The following is a description of a gene set: from publication Zhang L, Long W, Xu W, Chen X, Zhao X, Wu B (PMID 35669188) Mouse Gene Set: ZHANG_UTERUS_C7_EPITHELIAL2_CELL Table S2: Representative genes of each cell cluster species: Mus musculus, and this is the list of marker genes: Eif3c, Naaa, Ptma, Gm6136, Rps26-ps1, Lsm2, Atp5f1b, Sprr2g, Gipc1, Eif2s1, Ap2s1, Rpl35a-ps2, Cks1b, Tpm3, Cox5a, Elf3, Calr, Ly6a, Tomm5, Plpp2, Hmgn2, Abcf1, Ap2m1, Prom1, Psme2b, Timm13, Srsf3, Rrm1, Ap1m2, Lcn2, Lrrc59, Rpl38-ps2, Rpl22l1, Avpi1, Fuca2, M6pr, Clic1, Crip1, Bmyc, Ccdc12, Mad2l1, Dtymk (NCBI Gene Id 98609), Cttn, Rpl37rt, Eif6, Pglyrp1, Ccnd1, Rab32, Gm15501, Samm50, Dpy30, Tonsl, Cct3, Cib1, Smarca4, Fxyd3, 2200002D01Rik, Ormdl2, Stip1, Gm7536 (predicted gene 7536), Impdh2, Ybx1, Rps10-ps1, Atp5mc2, Nudcd2, Cisd1, Bcap31, Sat1 (spermidine/spermine N1-acetyl transferase 1), Ubl4a, Hnrnpu, Rps10-ps2, Elavl1, Ybx3, Ccdc124, Fxyd4 (FXYD domain-containing ion transport regulator 4), Tma7, Syngr2, Lap3 (NCBI Gene Id 66988), Xpnpep1, Pno1, Naca, Ywhah, Cct2, Acp1, Cdc42ep5, Metap2, Atp5mg, Mrps33, Padi4, Rpf1, Rpl7a, Ndufb7, Mrpl28, Rpl13a, Tagln2, Sdhd, Hsd17b12, Usp50, Urah, Por, Fam20c, Gale, Gadd45gip1, Sap18, Rps11, Rps27l, Gm8730, Ywhae, Rps6, Plscr1, Rpl28-ps1, Rnf128, Bzw1, Tpd52l1, Gapdh, Tmprss4, Gm8355, Rps10, Gars1, Uqcrc1, Gm9385, Fam107b, Cops5, Cct5, Gpx1, Rpl14-ps1, Llph, Tmem213, Mrps18a, Gm7730, Mrps21, Tmem208, Kif5b, Msmo1 (NCBI Gene Id 97453), Mtx2, Rn18s-rs5, Rpl7, Atp5mk, Rab25, Arpc1b, Cdc42se1, Timm23, Polr2f, Anxa4, Hnrnpm, Rps2 (ribosomal protein S2), Cacybp, Gm14539, F2rl1, Rpl15, Nme1, Snrpa1, Serpinb1a, Mtch2, Gm10036, Hnrnpa2b1, Ndufc1, Gm15421, Itga6, Ebp, Rnpep, Krt18, Ndufa9, Padi2, U2af1, Tmod3, Gm10177, Cbx1, Uchl3, Sfn, Psme3, Erh, Plet1, Ssu72, Rpl6l, S100a11, S100g (S100 calcium binding protein G), Gng12, Timm50, Padi1, Wfdc2, Mrto4, Atp5mf, Cystm1, Tgm2, Psmd14, Ube2e1, Taldo1, Prxl2a, Psmd1, Dhcr24, Ncoa7 (nuclear receptor coactivator 7), Phlda1, Prmt1, Golm1, Prdx3, Pomp, Cd2ap, Gm12191, Rpl17-ps10 (ribosomal protein L17, pseudogene 10), Sgms2, Creld2, Ruvbl2, Atp1b3, Ndufs4, Cox6c2, Prkab1, Lad1, Rps6-ps4, Mydgf, Tspan1, Polr3k, Snrpe, Mrpl36, Clca1, Tubb4b, Mrpl46, Uba52, Bccip, Uba52rt, Tomm22, Plxnb2, Arpc5, Rtn4, Ezr, Ndufb3, Cox5b, Atp2c2, Pkm, Plaur, Yrdc, Rps24-ps3, Ap2b1, Bace2, Ap1s1, Gm13436, Gm11249, Skp1, Pdzk1ip1, Snrpd1, Psmb5, Ctnna1, Gm5905, Tmem14c, Acsl5, Pfdn6, Gm15500, Ran, Ppp1r14b, Pgk1, Ddx1 (NCBI Gene Id 104721), Hprt1, Adss1, Ltf, Tm9sf2, Ncstn, Fmc1, Erhrt-ps, Rps18-ps5, Nsun2, Ccnb2, Gm3150, Brix1, Serbp1, Vars1, Fuca1, Arpc2, Muc4, Nap1l1, Hnrnpk, Gm3375, Lsm8, Ier3 (NCBI Gene Id 15937), Serp1, Snrpa, Cyba (NCBI Gene Id 13057), Cox7b, Gm5561, Perp, Ndufab1, Psma3, Rps7-ps3, Ostc, H3f3a, Nme2, Lsm3, Chchd2, Uqcrq, Mrps15, Gm9790, Eif3b, Timm8b, Ndufa12-ps (NADH:ubiquinone oxidoreductase subunit A12, pseudogene), Pa2g4, Sprr2a3, Adrm1, Gclm, Gm6394, Ranbp1, Ipo5, Macroh2a1, Rbm3, Ppia, Snx5, Rnaset2a, Ahsa1, Cyb5b, H2bc4 (NCBI Gene Id 97909), Sftpd, Vcp, Ap3s1 (NCBI Gene Id 11777), Fermt1, Gm10086, Rpl27, Higd1a (NCBI Gene Id 80431), Ube2l3, Rps11-ps1, Rer1, Emg1, Gm12338, Tmed10, Gm12918, Polr2k, Anpep, Dut, Uchl5, Atp5l2-ps, Gnb2, Tspan8, Prdx1, Gm8186, Fkbp4, Txn1, Spint2, Ldha, Mpc2, Eef1g, Pdia3, Nars1, Ndufa12, Sec11c, Mgst3 (microsomal glutathione S-transferase 3), Cdca3, Cmpk1, Cldn23, Gng5, Gm10221, Psma1, Gm4332, Rack1, Gm13680, Atp5f1e, Errfi1, Mrpl11, Pdia6, Psmc5, Slc25a5, Hsp90ab1, Rpl31-ps8, Srp9, Rpn1, Tuba4a, Pebp1, Tacstd2, Serpina1e (serine (or cysteine) peptidase inhibitor, clade A, member 1E), Trir, Actg1, Psma2, Sprr1a, Pigyl, Dstn, Mrpl15, Rps3a2, Cct8, Gm7600, Ndufb2, Fcf1, Tmbim6, Ssr4, Gm4366, Polr2l, Fkbp2, Psmb7, Sumo1, Ubl5, Gmds, Hnrnpa1, Psmd11, Nono, Mfsd4a, Psma5, Hnrnpc, Gm6807, Gm5436, Rps27a-ps3, Tuba1c, Sting1, Ifitm1, Rheb, Cbr2, Ncl, Gm5586, Hdgf, Eprs1, Ostf1, Capg, Psmb6, Gm10146, Canx, Idh3b, H2ax (H2A.X variant histone), Rps15-ps2, Uqcrb, Mrps25, Gtf3c6, Gspt1, Ndufs6 (NADH:ubiquinone oxidoreductase core subunit S6), Gsta4 (glutathione S-transferase, alpha 4), Birc5, Tmbim1, Fads2b, Eif1a, Prdx5, Tsg101, Actr2, Ndufa6, Rpl35a, G3bp1, Lman2, Ddost, Anxa2, Tcp1, Prap1, Eif4a1, Prelid3b, Sdf2l1, Ndufa5, Oaz1-ps, Rps13-ps2, Ddx39a, Uap1, Txnl1, Psmd12, Tmem176a, Ewsr1, Nsmce1, Mrps34, Gm12174, Ywhaz, Cfb, Eif3i, Commd1, Psmc4, Psenen, Ube2a, Clptm1l, Sae1, Mrps7, Rps23-ps1, Prelid1, Cfap298, Rps6-ps3, Gcsh, Ppp4c, Mrpl21, Snx7, Tcim, Snrpd2, Npm1, Nhp2, Mrpl42, Gm14303, Wdr1, Zfp706, Puf60 (NCBI Gene Id 72802), Atp5pf, Csnk2b, Gm10123, Gm9892, Hspa4, Psmc3, Ctnnb1, Chka, Pfn1, Cox8a, Anxa7, Wdr89, Calm3, Btf3-ps1, Eif4e2, Slc39a4, Atp5f1d, Tmc4, Lsm6, Eloc, Set, 1110004F10Rik, Elovl5, Etfa, Pdia4, Rpl34-ps1, 1810037I17Rik, Krt7, Gar1, Uqcc2, Gm6204, Ppm1g, Sem1, Gm14586 (predicted gene 14586), Reep5, Mrpl17, Ndufs5, Atp5mc1, C3, Rps18-ps3, Aldoa, Gm11478, Naa50, Rpl19-ps11, Mrpl12, Gm3788, Jup, Srsf1 (serine and arginine-rich splicing factor 1), Lsm7, Atp5mj, Kcnk1, Fdps, Chchd1, Hnrnpa3, Mrpl57, Sec61g, Klf6 (Kruppel-like transcription factor 6), Magoh, Cenpa, Cox7a2, Rpl19, Gm10288, Mdh2, Rpl36al (ribosomal protein L36A-like), Rpl5, Lsr, Enpp3, Car2, Tomm7, Atp5po, Dnajc15, Dynll1, Pgd, Hmgb1, Uqcr11, Cops4, R3hdm4, Rps16-ps2, Rps25-ps1, Alpl, Idh3a, Gm14165, Sec13, Fbl-ps2, Nrtn (neurturin), Ndufc2, Psenen-ps, Hnrnpf, Gm11687, Cdh1, Rpl8, Mrpl13, Tpd52, Zc3h15, Pak1ip1, Smdt1, Cxcl17, Eif2s2, Ythdc1, F3, Eif4g1, Dcxr, Pls3, F11r, Gm15772, Gm13835, Timm17a (NCBI Gene Id 21854), Spcs2, H2az1 (NCBI Gene Id 51788), Ak2, Cox7c, Hspa9, Snrpg, Hnrnpab, Mycbp, Gm9794, S100a10, Cct6a, Atp5f1a, Emc6, Pclaf, Mrps14, Atp5me, Naxd, Hspe1, Rpl27a, Mtln, Strap, Ndufa3, Psma7, Atp5pb, Fam3d, Rpl7-ps7, Cnbp, Gm10132, Spink12, Msx1, Phb1, Qsox1, Gm9843, Gm10039, Pdcd6 (NCBI Gene Id 18570), Psmd13, Uqcr10, Muc20, Atp6v1a, Mrps6, Rpl7l1, Hddc2, Gm7808, Ubqln1, Banf1, Ppih, Tbca, Dnajc2, Gm9294, Gm3699, Nop10, Eif4a-ps4, St14, Polr1d, Ass1, Npm3, Nudt21, Gm15459, Psme2, Cenpw, Psma6, Ckmt1, Atp5f1c, Naa10, Lsm4, Serinc2, Fut2, Armc10, Tuba1b, Ppa1, Sumo3, Gm10076, Slc44a4, Gsr, Wdr18, Arf1, Rnf7, Krtcap3, Ndufa13, Cldn7, Hsp90b1, Slc1a5, Krt8, Cldn3, Psat1, Gm11539, Rpl6, Hbegf (NCBI Gene Id 225370), Smim22, Tmem45b, Gtf2f2, Plp2, Phb2, Mrpl30, Clint1, Cd9, Dbi, Gprc5a, Btf3, Rpl36-ps2, Nfu1, Arpp19 (cAMP-regulated phosphoprotein 19), Gm5805, Tpt1-ps3, Snrpf, Smox, Psmd2, Mrpl52, Ets2, Gm8203, Pepd, Atp1a1, Tyms, Coa3, Anp32b, Bak1, Polr2j, Psmb2, Ndufa11, Cox6b1, Pfdn4, Pycard, Cndp2, Lamc2, Snhg3, Dctpp1, Cycs, Cct7, Ppp1ca, Dazap1, Gm13461, Ubl3, Net1, Cox14, Gm21399, Muc1, Myl12b, Rpl7-ps9, Rala, mt-Cytb, Eif3g, Park7, St13 (NCBI Gene Id 70356), Eny2, Mrpl51, Fuom, Tkt, Sprr2f, Sypl1, Gm8451, Ndufb8, Pop5, Mrps16, Elof1, Ceacam1, Cyc1, Golph3, Gm9493, Gadd45a, Spp1, Actn4, Gm6061, Mall, mt-Nd1, Mrpl18, Tmem238, Uqcrfs1, Ebna1bp2, Farsb, mt-Nd3, Cdc37, Vmp1, Bcat1, Atp5mc3, Rab11a, Alcam, Car12 (carbonic anhydrase 12), G6pdx, Txnl4a, Cd24a, Tex2, Rpsa-ps10, Cs, Hspd1, Vdac2, Zfand5, Rbis, Ndufb6, Gm6863, Bbln, Stoml2, Suclg1, Vamp8, Gm13611, Apex1, Nmt1, Chmp2b, Rpn2, Prp2rt, Ccdc34, Ptbp1, Las1l, Nol7, Psma4, Gm10250, Asah1, Rps17, Eif5a, Gltp, Tspo, Ndufs5-ps, Gm10275, Pdcd6ip, Cldn4, Ppil1, Ralbp1, Pfdn2, Trim15, Ube2n, Rad23b, Eef1d, Mif-ps4, Rpa3, Rpl3-ps1, Gm9800, Gm12350, Tpi1, Aqp5, Grpel1, Ddx39b, Ciao2a, Pigt, Rab5if, Pycr2, Anxa1, Bzw2, Sap18b, Eno1, Fkbp11, Ptges3, Rnaset2b, Ndufb4, Rpl35rt (ribosomal protein L35, retrotransposed), Gm16089, Denr, Fbl, Lsm5, Ube2c, Sfxn1 (NCBI Gene Id 70119), Psmd3, Ndufv2, mt-Co1, Rpl29, Lyar, Snrpd3, Gm10736, Emd, Arpc4, Gm10269, Krt19, Rpl18-ps2, Thyn1, Cox5b-ps, Gsto1, Manf, Txnrd1, Selenot, Psmc1, Selenoh, Rfk, Rps8, Vdac1, Rpl9-ps6, Slc40a1, C1qbp, Tomm40, Prr13, Psmb3, Mdh1, Pfdn1, Spc24 (NCBI Gene Id 67629), Rpl35, Hmgb2, Nudc, Mrpl20, Uqcrc2, Dnajb11, Jpt1, Epcam, Crb3, Ndufa4, Cyp51, Eif4a2, Gjb2, Rbbp7, Mrps18c, Nop58, Fam3c, Abracl, Commd2